The following is a description of a gene set: Human Gene Set: SU_LIVER Genes up-regulated specifically in human liver tissue. High-throughput gene expression profiling has become an important tool for investigating transcriptional activity in a variety of biological samples. To date, the vast majority of these experiments have focused on specific biological processes and perturbations. Here, we have generated and analyzed gene expression from a set of samples spanning a broad range of biological conditions. Specifically, we profiled gene expression from 91 human and mouse samples across a diverse array of tissues, organs, and cell lines. Because these samples predominantly come from the normal physiological state in the human and mouse, this dataset represents a preliminary, but substantial, description of the normal mammalian transcriptome. We have used this dataset to illustrate methods of mining these data, and to reveal insights into molecular and physiological gene function, mechanisms of transcriptional regulation, disease etiology, and comparative genomics. Finally, to allow the scientific community to use this resource, we have built a free and publicly accessible website (http://expression.gnf.org) that integrates data visualization and curation of current gene annotations. species: Homo sapiens from publication Su AI, Cooke MP, Ching KA, Hakak Y, Walker JR, Wiltshire T, Orth AP, Vega RG, Sapinoso LM, Moqrich A, Patapoutian A, Hampton GM, Schultz PG, Hogenesch JB (PMID 11904358), and this is the list of marker genes: FMO3 (flavin containing dimethylaniline monoxygenase 3), LECT2, SLC25A13, CRYGA, EXOC6B, SAA4, CTH, CFHR1, CYP1A2, DDT, LIPC, AKR1C4, CPN2, LPA, RDH16, CFHR4, UGT2B4, GPT, GALK1, C4BPB, SERPIND1, AFM, TAT, CFHR2, IGFALS (NCBI Gene Id 3483), CYP3A7, HAO1, MASP2, C8A, LRRC37A, GCKR, SLC22A1, ARG1, DHODH, GBA1, TFR2, SEC14L2, HABP2, CCL16, MBL2, SERPINC1, CYP4F11, SLC25A20, GCGR, C9 (complement component 9), F12, F9 (NCBI Gene Id 14071), APOF, SPP2, CPS1, SLC6A12, APCS, APOB, CRP, ARID1A, CPN1, RXRA, ITIH2